Given this list of marker genes PFN1, CAP1, ARPC2, ARPC5, WAS, OSTF1, RAP2B (RAP2B, member of RAS oncogene family), STAT6, LASP1, CDC42, ADAM8, TUT7, ELF4, ACTR3, CAPZA1, HCLS1, MSN, ADAM10, RAP1B, TGFB1, IQGAP1, ITGB2, EMP3 (NCBI Gene Id 2014), CLIC1, here is a description of the gene set: Human Gene Set: GNF2_MSN studied in species Homo sapiens Neighborhood of MSN moesin in the GNF2 expression compendium Neighborhood of MSN